Given this list of marker genes PALS2, FGFR3, RLBP1, NT5C3A, CHRNA1, PEX13, COL9A3, NEDD4L, SALL3, SV2C (synaptic vesicle glycoprotein 2C), ABCA1, SLCO4A1, H19, SLITRK1, RDH10, MYO5C, RNF19A, SERPING1, CPXM1, LINC01896, EPHA4, PROM1, NRARP, ZNF224, PPP1R17, C18orf54, RTTN, RALGAPA2, TLE1, RDH13 (retinol dehydrogenase 13), NELL2, OBSL1, ZNF516, AKAP7, GIMAP1, SIX1, LAMP5, NRIP3, LINC00997, SOCS6, here is a description of the gene set: Genes up-regulated in cancer stem cells derived from glyoblastoma tumors: CD133+ vs. CD133- cells. species: Homo sapiens Human Gene Set: BEIER_GLIOMA_STEM_CELL_UP Although glioblastomas show the same histologic phenotype, biological hallmarks such as growth and differentiation properties vary considerably between individual cases. To investigate whether different subtypes of glioblastomas might originate from different cells of origin, we cultured tumor cells from 22 glioblastomas under medium conditions favoring the growth of neural and cancer stem cells (CSC). Secondary glioblastoma (n = 7)-derived cells did not show any growth in the medium used, suggesting the absence of neural stem cell-like tumor cells. In contrast, 11/15 primary glioblastomas contained a significant CD133(+) subpopulation that displayed neurosphere-like, nonadherent growth and asymmetrical cell divisions yielding cells expressing markers characteristic for all three neural lineages. Four of 15 cell lines derived from primary glioblastomas grew adherently in vitro and were driven by CD133(-) tumor cells that fulfilled stem cell criteria. Both subtypes were similarly tumorigenic in nude mice in vivo. Clinically, CD133(-) glioblastomas were characterized by a lower proliferation index, whereas glial fibrillary acidic protein staining was similar. GeneArray analysis revealed genes to be differentially expressed by these two subtypes. Together, our data provide first evidence that CD133(+) CSC maintain only a subset of primary glioblastomas. The remainder stems from previously unknown CD133(-) tumor cells with apparent stem cell-like properties but distinct molecular profiles and growth characteristics in vitro and in vivo. from publication Beier D, Hau P, Proescholdt M, Lohmeier A, Wischhusen J, Oefner PJ, Aigner L, Brawanski A, Bogdahn U, Beier CP (PMID 17483311)